Given this list of marker genes PON1, NTSR1, ANGPTL3, OGG1, GDA, PGAM1, LDHA, ABHD16A, SMPD2, UPP1, PLA2G4D, STAT3, ACOT7, PDE1A, INPP5F, ENO4, MGAT1 (NCBI Gene Id 4245), PPP2CA, TPI1, KAT2B, PGK2, EP300, ABHD16B, OGT, NUPR1, DERA, HK2, PRKAG1, PLA2G5, INSR, PFKFB2, BCL2L13, INS, PDE8A, ENO3, SUCLG1, ENPP1, NTHL1, PDE9A, PLA2G4E (NCBI Gene Id 388117), EIF6, ABHD12B, ENTPD4, IFNG, MTOR, MFSD8 (NCBI Gene Id 256471), IER3, PKM, PGM1, NUDT16, PLCB1 (phospholipase C beta 1), PDE4C, PNP, ZBTB20, ENTPD3, BPGM (bisphosphoglycerate mutase), ENO2, PLPP6, GALT, ENTPD1, PDE8B, TDG, GALK1, ENPP6, PRKACA, PDE7A, SUCLG2, NUDT19, ETNPPL, AMPD3, SMPDL3B, LIPG, PDE5A, NUDT3 (NCBI Gene Id 11165), NUDT4B, NEIL2, DHTKD1, NT5C1A, PFKM, PRKAG2, SLC4A1, GIT1, GPCPD1, XDH, PDE7B, IGF1, GALM, UCHL1 (ubiquitin C-terminal hydrolase L1), NT5M, ABHD12, NUDT15, TIGAR, ARNT, PLA2G6, PRKCD, PRKAA1, PRKAG3, FOXK2, LDLR, SMPD3, NT5C2, PSEN1, PLCG1, NUDT7, ENTPD8, PKLR, PLD2, PLA2G7, SRC, NUDT18, NUDT5, DDIT4, COL6A1, MLYCD, SMPDL3A, MLST8, VNN1, GSK3A, PLCG2, LIPC, GDPD1, PFKFB1, ZBTB7A, P2RX7, PRKAA2 (NCBI Gene Id 5563), HPRT1, PLA2G4A, PRTFDC1, TREX1, APP, MLXIPL, ACTN3, UPP2, NUDT9, UPB1, NUDT11, SMPD1, PNLIPRP2, ACAT1, ABHD6, NAPEPLD, PPARA (peroxisome proliferator activated receptor alpha), PGAM2, ALDOA, ENPP7, IDH1, PLA2G15, DPYS, PLBD1, MTCH2, PRXL2C, ITPA, PNPLA8, PFKP, ABCD1, PLA2G4F, PDXP, NUDT12, VCP, GDE1, CBFA2T3, SUCLA2, GCK, FOXK1, GAPDHS, LIPA, PGK1, PLBD2, UCP2, FLCN, PFKFB3, DCTPP1, GALE, NUDT13, PLA2G10, NUDT17, SMUG1, PLA2G4C, PDE4B, HIF1A, PLB1, ARL2, ADA, PDE4A, SMPD4 (NCBI Gene Id 94852), OGDH, APOA2, PLD1, OGDHL, ENO1, GPD1, PGAM4, FKRP, UNG, PNPLA6, PDE4D, GPD1L, PNPLA7, HK1, PLA2G4B, ENTPD7, HKDC1, FITM2, NUDT10, GDPD3, SIRT6, PFKL, PDE2A, ADPGK, MBD4, TRIM63, NUDT4, NUDT8, ENTPD2, FBP1, DPYD, DNPH1, SARM1, HDAC4, GPI (NCBI Gene Id 2821), HINT1, ENPP3, DUT, PRDX6, HK3, SCARB1, ENPP2, ENTPD5, APOC1, APOC2, RPTOR, NCOR1, ALDOC, SLC4A4, GAPDH, JMJD8, HTR2A, ALDOB, NT5E, CNP, TYMP, FHIT, PDE10A, SLC2A6, NT5C, NT5C1B, NEIL1, SAMHD1, here is a description of the gene set: The chemical reactions and pathways resulting in the breakdown of organophosphates, any phosphate-containing organic compound. species: Homo sapiens Human Gene Set: GOBP_ORGANOPHOSPHATE_CATABOLIC_PROCESS